Given this list of marker genes CTSH, VAMP8, POLR3K (NCBI Gene Id 51728), PGD, RNF130, MNDA, PLEKHB2, TSG101, ZNF804A, PPT1, SQSTM1, AKIP1, ETFA, EIF4G1, CREG1, SDCBP, STAM2, GLB1, SERF2, GDE1, ANXA5, ATP6V1B2, ACO2, TUBA1C, VDAC1, RNASE6, IFNGR1, COX8A, DYNC1I2, MLX, GCLC, RAB31, AVPI1, VIM, CLEC7A, CEBPA, ORAI3, MFN2, CLTA, ZNF267 (zinc finger protein 267), RXRA, AASDHPPT, PLOD1, NCF2, CSNK2B, AP2S1 (NCBI Gene Id 9161), LARP4B, CTSB, KEAP1, NDUFA8, HSBP1, CSNK2A1, CALM2 (NCBI Gene Id 805), PYGL, TBC1D12, SNX1, TAX1BP3, GABARAP, PSEN1, TIMM8B, FCGRT, TXNRD1 (thioredoxin reductase 1), SLC7A8, BASP1, ZMIZ1, WSB2, MREG, CCR1, CTSC, MTMR6, DUSP3, FGL2, PSMB5, PRKAR1A, ZMPSTE24, TMCO1, MACROH2A1, CANX, LIMS1, ATP6V1E1, FOCAD, SRC, RAB7A, KIAA0930, GPX1, DERA, FTL, PGAM1, STAC, DCAF7, CD74, LAP3, OPN3, VPS41, UBE2A, DPYD, CD63, CYREN, GHITM (NCBI Gene Id 27069), MGAT2, SLC30A1 (NCBI Gene Id 7779), SYNGR2, GSTP1, HACD3 (NCBI Gene Id 95112), LIPA, MKLN1, HLA-DRB1, ALDH3A2 (NCBI Gene Id 224), SPG21, MTHFD2 (methylenetetrahydrofolate dehydrogenase (NADP+ dependent) 2, methenyltetrahydrofolate cyclohydrolase), ACP5, TM9SF2, IDH1 (NCBI Gene Id 3417), TALDO1, CYCS, NFE2L2, NFE2L1 (NCBI Gene Id 6937), PRDX1, CST3, LAMP2, VAMP3, ISOC1, PLCG2 (phospholipase C gamma 2), TGFBI, STX7, SLC1A5, ITPRID2, ATP6V0B, REEP5, CLASP2, DYNLL1 (dynein light chain LC8-type 1), BCKDK, ATP6AP2, PRKCD, GNG5, EXOC1, WDFY3, CLIC4, GNG10, TUBA1B, CSTA, ATP6V0E1, ATP6V1D, ATP5F1B, PI4K2A, CSTB (NCBI Gene Id 1476), LAMTOR3, HMGCL, ARMT1, FLVCR2, TM6SF1, GRN, AP2M1, BET1, DAPK1, MFSD1, RAB21, NRGN, LAMTOR2, RAB13, S100A11, SLC31A2, MGRN1, GSN, GLA, SNAP29, RNH1, SYK, M6PR, KCTD5, TM9SF1, MFAP1 (NCBI Gene Id 4236), CTNNA1, SMC2, UQCR10, ANXA2P2, SH3BGRL, TMEM33, CD58, UTP14C, LY96, MAN2B1, IFI30, CAPRIN1, HLA-DRA, TIMM17A, ARL8B, HSPA1A, NPTN, YBX3, GLRX2, ITGAX, RCBTB2, HLA-DMA, TIGAR, PRDX3, RHEB, SMCO4, HTT, ST14, here is a description of the gene set: from publication Abbas AR, Baldwin D, Ma Y, Ouyang W, Gurney A, Martin F, Fong S, van Lookeren Campagne M, Godowski P, Williams PM, Chan AC, Clark HF (PMID 15789058) Immune cell-specific expression is one indication of the importance of a gene's role in the immune response. In order to identify such patterns, we set out to broadly profile gene expression in a variety of immune cells. Genes down-regulated in comparison of naive CD4 T cells versus unstimulatd dendritic cells (DC). Human Gene Set: GSE22886_NAIVE_CD4_TCELL_VS_DC_DN species: Homo sapiens